The following is a description of a gene set: species: Homo sapiens Human Gene Set: chr3p25, and this is the list of marker genes: PRRT3-AS1, BTD, MTCO1P5, SLC6A11, NUP210P2, RAF1, MKRN2OS, GRIP2, CSTBP1, DPH3, IFT122P1, TPRXL, TIMP4, XPC, RNU6-454P, PPARG, SRGAP3-AS2, MRPS25, LMCD1-AS1, SRGAP3-AS3, RPS3AP53, ATG7, PRRT3, SH3BP5-AS1, RNU6-882P, SRGAP3-AS4, THUMPD3, LINC00620, ARPC4, DUSP5P2, FANCD2OS, SEC13, RHBDF1P1, CRIP1P1, SH3BP5, FANCD2, ATP2B2-IT2, JAGN1, BRK1, LINC02922, RPUSD3, BRPF1, RPS24P10, ATP2B2, LINC02011, FBLN2, SLC6A1, EMC3-AS1, ANKRD28, OXNAD1, FGD5P1, THAP5P2, ENSG00000281863, RNU6-377P, LSM3, EAF1, HMGN2P7, SETD5, RNU6-670P, GSTM5P1, RN7SL110P, IMPDH1P8, ATP2B2-IT1, SLC6A1-AS1, IL17RE, TMEM43, IRAK2, EAF1-AS1, ARPC4-TTLL3, MARK2P14, TAMM41, LINC01267, RNA5SP123, C3orf20, TTLL3, ENSG00000302535, TMEM40, PRR3P1, MIR563, CHCHD4P4, NR2C2, LINC02022, SSUH2, RPL32, SRGAP3, OXTR, GHRL, SYN2, SRGAP3-AS1, METTL6, RPL39P17, COLQ, THUMPD3-AS1, LINC00606, VGLL4, COL6A4P1, CHCHD4, IL17RC, CYCSP10, RN7SL4P, CAV3, CAPN7, RPL13AP27, PFDN1P1, LMCD1, OGG1, HACL1, HDAC11-AS1, HRH1, GHRLOS, TADA3, CCDC174, CAND2, MKRN2, FGD5-AS1, LHFPL4, RNU4ATAC17P, RBSN, FANCD2P2, TSEN2, CPNE9, IQSEC1, WNT7A, RNU6-905P, CIDECP1, RNU6-1024P, CYCSP11, CYCSP12, TATDN2, RNA5SP124 (NCBI Gene Id 100873394), GALNT15, CAMK1 (NCBI Gene Id 8536), MIR378B, FGD5, CRELD1, XPC-AS1 (XPC antisense RNA 1), LINC00852, MIR3134, RN7SL147P, KRT18P17, HDAC11, MIR885, MIR4270, OR7E122P, SNORA7A, VN1R20P, PGAM1P4, CIDEC, SLC6A6, NUP210, EMC3, ACTG1P12, VHL, RAD18, MTMR14, VN1R21P